The following is a description of a gene set: A G protein-coupled receptor signaling pathway in which the signal is transmitted via the activation of adenylyl cyclase activity which results in an increase in the intracellular concentration of cyclic AMP (cAMP). This pathway is negatively regulated by phosphodiesterase, which cleaves cAMP and terminates the signaling. studied in species Homo sapiens Human Gene Set: GOBP_ADENYLATE_CYCLASE_ACTIVATING_G_PROTEIN_COUPLED_RECEPTOR_SIGNALING_PATHWAY, and this is the list of marker genes: GSK3A, GALR2, CXCL11, UCN3, ADGRD2, RAPGEF4, MGRN1, TAAR6, S1PR1, ADGRL1 (NCBI Gene Id 79732), GPHA2, DRD3, LPAR3, GPR4, ADCY5, PRKAR2B, GPR12, ADGRL3, GPR78, ADCY3 (adenylate cyclase 3), PTHLH, CHGA, GHRH, OR1E3, ADGRG5, PTH1R, ADCY1, DRD5, GCG, ABCA1, ADGRG6, GPHB5, ADGRB1, OR5AN1, OR51E2, PTGER2 (NCBI Gene Id 63381), GIP, ADGRF5, MAS1, GCGR, GPRC6A, TCP11, ADGRG1, ADGRL4, PF4, GPR157, RAPGEF3, MRAP2, ADGRG4, ADGRF2P, GNA13, ADORA2B, ADCY7, GPR6, ADRB1, ADGRE5, GPR62, RAMP2, LPAR2, ADGRE2, CALCB, ADCY8, S1PR2, APP, MC4R, GALR1, ADGRB2, MRAP, PDE4D, ADCYAP1, ADM2, PDE4B, PDE4A, ADGRF4, VIPR2, PDE10A, ADM (NCBI Gene Id 133), CNR2, ADCY2, MAPK7, GPR161, MC5R, ADRA1A, OR1G1 (NCBI Gene Id 8390), RAMP3, APLP1, GIPR, RXFP2, ADGRE3, PTGFR, ADRA2A, HTR6, GPR101, ADRB2 (NCBI Gene Id 154), GNB1, CXCL9, TAAR9, GNAQ, ADGRG7, POMC, TAAR1 (NCBI Gene Id 134864), GPR26, GNAL, ADCY10, PTGER4, S1PR4, GPR61, GPR65, LHCGR (luteinizing hormone/choriogonadotropin receptor), TSHR (thyroid stimulating hormone receptor), GHRHR, ADGRE1, PLN, RAPGEF2, ADRA1B (NCBI Gene Id 147), ADGRB3, PRKCA, FSHR, PTH, GPBAR1, ADORA2A, ARRDC3, ADCY4, ADGRG2, DGKQ, PTGER1, GLP1R, PDE3A, PTGER3, MC1R, UCN2, PRKAR1A, CNR1, CALCRL, MC3R, PRKAR2A, AKAP6, NHERF1, S1PR5, SCT, ATP2B4, DRD1, ADGRF3, IAPP, VIPR1, PRKACA, HTR5A, FFAR4, TBXA2R, GNAS, PDE2A, ADGRD1, CXCR3, TAAR5, ADCY9, RIT2, MRGPRD, GPR119, GPER1, CALCA, RXFP1, VIP, CXCL10, PRKAR1B, CALCR, ADRB3 (NCBI Gene Id 94406), ADGRF1, ADCYAP1R1, CRHR1, HTR4, ADRA1D, LPAR1, ADGRL2, S1PR3, HTR7, ADM5, ADCY6, MC2R, RAMP1, RACK1, CRTC3, GPR68, GNAI2, SCTR, ADGRG3, PDE3B, NOS1, PTGIR, GPR3, GNG2